Given this list of marker genes Pygb, Pdxdc1, Mtarc1, Sds, Shmt1, Gad1, Accsl, Got1, Nfs1, Kyat3, Srr, Got1l1, Hdc (histidine decarboxylase), Sdsl, Pygm, Sptlc2, Gpt, Agxt, Abat, Pygl, Cth, Sgpl1, Agxt2, Pdxk, Plpbp, Gad2, Shmt2, Gcat, Mtarc2, Phykpl, Gldc, Cisd1, Psat1, Accs, Alb, Pnpo, Gadl1, Csad, Alas1, Got2, Aadat, Sptlc1, Alas2, Kynu, Thnsl2 (threonine synthase-like 2 (bacterial)), Sptlc3, Tat, Cbs, Etnppl, Oat, Scly, Kyat1, Ddc, Gpt2, Mocos (molybdenum cofactor sulfurase), here is a description of the gene set: Binding to a vitamin B6 compound: pyridoxal, pyridoxamine, pyridoxine, or the active form, pyridoxal phosphate. species: Mus musculus Mouse Gene Set: GOMF_VITAMIN_B6_BINDING